The following is a description of a gene set: species: Homo sapiens Steroidogenic pathway Human Gene Set: WP_STEROIDOGENIC_PATHWAY, and this is the list of marker genes: CYP11A1, CYP19A1, STAR (NCBI Gene Id 6770), HSD3B1, HSD17B1, CYP17A1